Given this list of marker genes Sftpa1, Sirpb1b (NCBI Gene Id 668101), Sirpb1c, Fyb1, Skap2, Tyrobp, Gm5150, Sftpd, Sirpd, Sirpa, Ptk2b, Sirpb1a, Grb2, Cd47, here is a description of the gene set: Mouse Gene Set: REACTOME_SIGNAL_REGULATORY_PROTEIN_FAMILY_INTERACTIONS species: Mus musculus Signal regulatory protein family interactions